Given this list of marker genes Ocrl, Inpp5f (inositol polyphosphate-5-phosphatase F), Pip4p2, Inppl1, Mtm1, Inpp5d, Mtmr11, Pip4p1, Inpp5b, Chrm5, Mtmr3, Mtmr4, Pten, Mtmr2, Fig4, Synj1, Sacm1l, Inpp5a, Inpp4b, Mtmr1, Mtmr12, Inpp5k, Inpp5j, Mtmr6, Mtmr9, Inpp5e, Synj2, Mtmr7, Mtmr10, here is a description of the gene set: Mouse Gene Set: GOBP_PHOSPHATIDYLINOSITOL_DEPHOSPHORYLATION species: Mus musculus The process of removing one or more phosphate groups from a phosphatidylinositol.